Given this list of marker genes MIR146A, MST1L, SOCS3 (suppressor of cytokine signaling 3), INPP5F, LEPROT, PIBF1, IL6, SOCS2, NEUROD1, IFNG, BCL3, PTK6, PTK2B, CAV1, JAK3, GHR, PTPRD, GH2, DOT1L, PIGU, CSHL1, CSF2RA, CYP1B1, PARP14, NOTCH1, CSH2, ELP2, USP1, GBP7, IL7R, IFNAR2, IL26, IFNAR1, LEP, VHL, OCIAD1, PTPRC, F2 (coagulation factor II), SH2B3, EP300, MIR9-1, PRLR, MST1, CSH1, CALM1, WDR48, CISH, ERBB4, PTPN2, HMGA2, KIT, PRL, SOCS1, HES5, NF2, ERCC6, IFNL1, CRLF3, RAC1, JAK2, EPHB2, GH1, OCIAD2, IL10, ADIPOR1, IL10RB, F2R, IL9, HES1, HGS, IL10RA, CAMK2A, TYK2, MIR221, EGF, GADD45A, CENPJ, IL5, DAB1, here is a description of the gene set: studied in species Homo sapiens Any process that modulates the frequency, rate or extent of receptor signaling via JAK-STAT. Human Gene Set: GOBP_REGULATION_OF_RECEPTOR_SIGNALING_PATHWAY_VIA_JAK_STAT